The following is a description of a gene set: Although multiple myeloma (MM) is a unique entity, a marked heterogeneity is actually observed among the patients, which has been first related to immunoglobulin (Ig) types and light chain subtypes and more recently to chromosomal abnormalities. To further investigate this genetic heterogeneity, we analyzed gene expression profiles of 92 primary tumors according to their Ig types and light chain subtypes with DNA microarrays. Several clusters of genes involved in various biologic functions such as immune response, cell cycle control, signaling, apoptosis, cell adhesion, and structure significantly discriminated IgA- from IgG-MM. Genes associated with inhibition of differentiation and apoptosis induction were up-regulated while genes associated with immune response, cell cycle control, and apoptosis were down-regulated in IgA-MM. According to the expression of the 61 most discriminating genes, BJ-MM represented a separate subgroup that did not express either the genes characteristic of IgG-MM or those of IgA-MM at a high level. This suggests that transcriptional programs associated to the switch could be maintained up to plasma cell differentiation. Several genes whose products are known to stimulate bone remodeling discriminate between kappa- and lambda-MM. One of these genes, Mip-1alpha, was overexpressed in the kappa subgroup. In addition, we established a strong association (P =.0001) between kappa subgroup expressing high levels of Mip-1alpha and active myeloma bone disease. This study shows that DNA microarrays enable us to perform a molecular dissection of the bioclinical diversity of MM and provide new molecular tools to investigate the pathogenesis of malignant plasma cells. from publication Magrangeas F, Nasser V, Avet-Loiseau H, Loriod B, Decaux O, Granjeaud S, Bertucci F, Birnbaum D, Nguyen C, Harousseau JL, Bataille R, Houlgatte R, Minvielle S (PMID 12623842) studied in species Homo sapiens Up-regulated genes discriminating multiple myeloma samples by type of immunoglobulin they produce: IgG vs IgA. Human Gene Set: MAGRANGEAS_MULTIPLE_MYELOMA_IGG_VS_IGA_UP, and this is the list of marker genes: INPP1, GAS1, NAA10, SRF, PPP1CA, COL16A1, DARS1, PSG2, ANXA1, CST3, JAG2, BEX3, AP1B1, DCTN1 (dynactin subunit 1), ALG2, LIPE, FAH, IGHV1OR15-1, ABCA7 (ATP binding cassette subfamily A member 7), GATA2